Given this list of marker genes FAIM, CXCL6, HSPH1, NAGA, FEM1C, IGF2BP2, SIDT2, SLC25A11, BPNT2, OLFML2A, ANXA10, DNAJC10, ABCE1, EEF1E1, ATP1B3, JPT1, HAS2, AP3S2, CRTAP, LTBP1, HELZ, CALM2, SEC14L1, MT1E, BAALC, COX8A, GNG12, CD59, GCNT1, LRRC15, OIP5, PFKM, ADAM19, OLFML3, PIMREG, HOMER3, PLXNA1, UGGT1, SLFN12, TMEM100, KAZN, STAM2, CYCS, FKBP1B, CACNA2D3, CENPN, BACE1 (beta-secretase 1), NAV2, MCM2, RAD51, WSB2, HAUS6, RECK, DNA2, TIMELESS, ARPC1A, THBS1, FBXL2, CENPS, MAB21L2, HYI, NUDT21, TFPI2, ELOVL6, SLC25A24, SLC38A6, NT5DC2, GPALPP1, OSBPL11, REXO2, ZKSCAN7, CBS, RAD23B, GAS1, DENND5A, FABP5, PLGRKT, COPZ2, DNMT3B, GTF3C1, CHST15, C10orf88, COL4A5, CDC6, GATA2, CREG1, IGFBP5, SRI, ECT2, ALDH2, SLC31A2, DMXL2, MTG1, MMD, HNRNPH3, ZCCHC24, OXSR1, ATP2C1, MOXD1, PDGFA, PDLIM2, GTF2E1, SEC11A, SRD5A1, TIPIN, BCHE, FGF2, CTNND1, NECTIN3, BCAP29, LRP12, LDB2, PAPPA (NCBI Gene Id 5069), PTRH2 (NCBI Gene Id 51651), KIF4A, CHSY1, RAPGEF4, TWF1, GSTT2, ICMT, RAPGEF2, HSPA4L, TEAD3, RAB1A, IMPA1, COL6A2, BID, SLC25A14, RAD51AP1, PCDH9, CEP55, DPYSL3, CRISPLD2, MRPL35, CARS1, NDC80, AAMDC, MAD2L1 (NCBI Gene Id 4085), EMC3, FANCL, TPST1, NEFM, POP7, KIAA1549L, SCD, NDUFA6, FAM50A, STAG3L4, JAG1, YOD1, BTBD3, STK3, CNN3, MAGEH1, KLF4, STRAP, MYRF, PTBP3, PTGS1, UST, APOOL, ARHGAP29, EDNRA, MGAT4B, DSG2, SMAD4 (SMAD family member 4), SLC35A5, SLIT2, GLRB, KLF10, FBXW11, ANKRD17, POLR2L, ERCC1, SERPINB8, NID1, PLSCR4, PDLIM1, DOK5, HNRNPAB, MOB1A, AEBP1, ZDHHC7, HDAC2, FAH, PGM3, CHEK2, TAGLN2, DEPDC1, JADE3, RGS2, SS18, SFRP1, PFDN6, SCG5, CAMSAP2, GCLM, TMEFF1 (NCBI Gene Id 8577), GYG2 (NCBI Gene Id 8908), ERI2, here is a description of the gene set: Human Gene Set: GSE1460_NAIVE_CD4_TCELL_ADULT_BLOOD_VS_THYMIC_STROMAL_CELL_DN Subpopulations of human fetal thymocyte and circulating naïve T cells were obtained through FACS sorting, including CD3-CD4+CD8- intrathymic T progenitor cells (ITTP), CD3intCD4+CD8+ \double positive\ thymocytes (DP), CD3highCD4+CD8- \single positive\ thymocytes (SP4), CD3+CD4+CD8-CD45RA+CD62L+ naive T cells from cord blood (CB4+), and CD3+CD4+CD8-CD45RA+CD62L+ naive T cells from adult blood (AB4+). Genes down-regulated in naive CD4 T cells from adult blood versus thymic stromal cells. studied in species Homo sapiens from publication Lee MS, Hanspers K, Barker CS, Korn AP, McCune JM (PMID 15210650)